The following is a description of a gene set: Enables the transfer of an ion from one side of a membrane to the other. Mouse Gene Set: GOMF_MONOATOMIC_ION_TRANSMEMBRANE_TRANSPORTER_ACTIVITY studied in species Mus musculus, and this is the list of marker genes: Clcn6, Slc34a2, Tmem120a, Chrnb1, Atp13a5, Nherf1, Stim1, mt-Nd6, Slc9b2, Best1, Kcnj6, Slc13a5, Stoml1, Ywhah, Trpc1, Cnga3, Slc24a3, Slc22a5, Cacng6, Slc31a1, Nrxn1, Snta1, Scn5a, Slc18b1, Cacng1 (calcium channel, voltage-dependent, gamma subunit 1), Wnk2 (NCBI Gene Id 75607), Slc26a8, Atp6v1h, Commd1, Tmco1 (transmembrane and coiled-coil domains 1), Atp6v1c2, Atp5me, Rangrf, Flna, Orai2, Pkd1, Atp13a1, Ccdc51, Kcnk2, Slc5a1, Slc6a18, Slc30a3, Cabp2, Kcnj2, Trpc5, S100a6, Atp5pd, Kcnc4, Tmem168, Slc1a7, Ano8, Slc15a4, Asic2, Lrrc8e, Slc34a1, Scn2a, Slc32a1, Grm7, Abcc8, Scn3a (NCBI Gene Id 381367), mt-Nd5, Piezo1, Cacna2d4, Gabrg1, Atp2c2, Gabra5, Atp6v1g1, Cav3, P2rx7, Slc30a4, Kcnmb2, Nrxn3, mt-Atp8, Kcnh3, Slc1a4, Tfrc, Fxyd4, Kcnb2, Slc8b1, Gpd1l, Ucp3, Atp6v0e2, Atp6v1e2, Cacng8, Slc46a1, Hcn3, Magt1, Sfxn1, Sfxn3, Kcna4, Slc12a9, Lrrc8c, Hamp2, Atg5lrt, Kcne2, Kcng1, Atp6v1a, Grik1, Gria1, Calm3, Slc6a14, Micu3, Kcna7, Slc13a3, Chrna6, Grm3, Kcne3, Camk2d, Faim2, Vdac3, Scnn1g, Cacng2, Slc5a4a, Slc25a13, Gabra2, Slc25a27, Kcnj4, Slc25a28, Clca1, Slc2a13 (NCBI Gene Id 239606), Amigo1, Fkbp1b, Ywhae, mt-Nd4l, Pacsin3, Kcnu1, Atp2b2, Slc6a8 (solute carrier family 6 (neurotransmitter transporter, creatine), member 8), Atp6v0d2, Slc6a12, Slc15a1, Slc38a4, Rem2, Slc17a3, Pkd2l1, Ano1, Mlc1, Kcns2, Scn4a, Clca4a, Slc39a13, mt-Nd1, Trpm6, Stom, Grin2c, mt-Co3, Slc12a4, Grin3a, Slc19a1, Grin3b, Tmc8, Kcnk7, Akap9, Tpcn1, Slc9c1, Trpc2, Vti1b (vesicle transport through interaction with t-SNAREs 1B), Cacna1a, Kcnj12, Slc26a9 (solute carrier family 26, member 9), Kcnb1, Kcnt1, mt-Nd2, Calhm6, Slc2a4, Slc26a11, Atp5f1a, Nalf2, Trpv3, Cacng7 (calcium channel, voltage-dependent, gamma subunit 7), Slc10a4-ps, Slc12a5, Apol10b, Lrrc38, Kcnh2, Trpm1, Lamp1, Slc12a3, Kcnj3, Tmem120b, Scn4b, Panx3 (NCBI Gene Id 71631), Slc47a1, Slc10a2, Slc17a7, Zdhhc13, Htr3b, Atp2c1, Gabrr3, Gabrr2, Chrna5, Tmem150c, Slc30a7, Sfxn4, Lrrc26, Kcng4, Prss30, Hcn4 (NCBI Gene Id 330953), Crisp4, Clic6, Slc6a6, Fxyd3, Slc4a2, Slc22a3, Fgf11, Mcub, Kcna2, Slc10a4, Cngb3, Atp6v1f, Slc30a9, Atp4a, Fgf14, Tmem37 (NCBI Gene Id 98701), Kcnn1, Atp5mc2, Slc18a3, Oca2, Trpm2, Prkg1, P2rx5, Slc4a10, Clca4b, Kcnab3, Slc13a2, Stimate, Romo1, Scn9a, Slc30a5, Pkd2, Slc25a12, Kcnk6, Slc10a5, Ano5, Sgk2, Gabrr1, Clcn1, Scn8a, Kcnk13, Pex5l, Nipa2, Cox5a, Sumo1, Apol11b, Atp2a1, Slc24a4, Cox7a1, Slc41a1, Kcnh1, Orai1, Slc9a4, Phpt1, Calhm4, Gria4, Tmbim4, Kcnc3, Atp12a, Chrna10, Kcnmb1, Slc6a2, Atp6v1e1, Clic5, Slc39a11, Slc34a3, Kcnc2 (potassium voltage gated channel, Shaw-related subfamily, member 2), Slc26a2, Cldn4, Slc18a2, Mcoln3 (NCBI Gene Id 22316), Slc25a14, Slc20a1 (solute carrier family 20, member 1), Slc28a1, Glra1, Gabrb2, Clca3a1, Slc9a5 (NCBI Gene Id 277973), Slc12a1, Slc18a1, Slc28a2, Atp13a2, Sec61a1, Cftr, Trpv4, Lrg1, Atp1b2, Stx1a, Apol9b, Gjc1, Slc39a14, Clcc1, Gpm6a, Slc41a2, Kcnd1, Kcnj10, Kcnj13, Gm5134, Kcne4, Chrng, Slc4a8, Apol8, Chrna1, Slc30a10, Slc24a2, Calm1, Orai3, Kcnh6, Tpcn2, Vamp8, Otop1, Slc39a7, Trpm8, Slc16a1, Atp5f1b, Slc6a20a, Slc9a9, Cacna1f, Asic4, Trpm7, Slc4a4 (solute carrier family 4 (anion exchanger), member 4), Scn10a, Cav1, Cldn17, Fgf13, mt-Atp6, Chrna7, Tmc1, Trpv6 (NCBI Gene Id 64177), Clca3a2, Micu1, Tmc2, Snap25, Slc23a2, Itpr3, Kcnk18, Trpc3, Nos1, Sfxn5, Ctns, Gabrb1, Atp6v1d, Clic1, Grik3, Atp7a, Atp2a3, Tmem38b, Ttyh3, Slc5a7, Hamp, Cacnb4, Prkcz, Kcnk9 (potassium channel, subfamily K, member 9), Slc6a7, Cacng5, Gem, mt-Cytb (NCBI Gene Id 17711), Tmc6, Kcnk3, Slc17a6, Tspoap1, Slc26a7, Gabrq, Slc11a1, Lrrc8b, Slc30a2, Mfsd2a, Chrnd, Atp6v1c1, Fxyd6, Atp5po, Bsnd, Chrnb3, Kcns3, P2rx6, Grin2d, Kcnc1, Chrnb2, Nedd4, Tmc3, Slc5a4b, Cnga1, Scn1a (NCBI Gene Id 227987), Cnnm2, Ndufs8, Cacna1g, Aqp1, Ndufv1, Glra2, Chrna4, Kcna10, Slc38a2, Tmem63c, Anxa5, Kcnj8, Mcoln1, Nedd4l, Micu2, Lasp1, Gabrp, Kcnmb3, Trpa1, Grik5, Slc17a8, Atp6v0b, Vdac2, Ndufv2, Slc15a2, Kcnk1, Slc9a2, Atp4b, Ndufs3, Gja1, Abcc9, Kcnf1, Slc30a8, Piezo2, Atp5f1e, Trpm4, Kcnk16, Slc26a1 (NCBI Gene Id 231583), Ano6, Slc5a2, Otop3, Slc30a1, Mcoln2, Kcnd3, Atp6v0a1, Itgav, Atp6v1g2, Gpld1, Pcsk9, Sgk3, Catsper1, Kcne1, Adrb2, Dlg1, Tmem63b, Gabrg3, Kcnj1, Sfxn2, Slc24a1, Calhm1, Kcne5, Atp1b3, Slc5a3, Cacna1s, Fxyd5, Hvcn1, Vdac1, Slc4a7, Clcn5, Slc41a3, Cacng3, Hcn2, Chrm5, Gabre, Atp1b1, Rasa3, Slc6a1, Kcng3, Itpr2, Gabrg2, Slc11a2, Wnk3, Oprm1, Ank2, Slc38a7, Slc46a3, Slc6a3, Calhm5, Clic4, Slc26a4, Htr3a, Gpr89, Kcnq2, Slc39a5, Stx7, Atp2b4, Cox4i2, Slc29a4, Slc4a3, Atp5mc3, Glrb, Atp5f1c, Slc39a8, Nalcn, Calhm3, Nipal2 (NCBI Gene Id 77238), Pkdrej, Scnn1a, Mcu, Slc39a4, Kcnh8, Slc9a3, Nipal1, Cacnb3, Kcnq3, Kcna5, Cacnb1, Slc6a11, Slc4a9, Ryr3, Atp6-ps, Slc6a4, Uqcrh, Cacna1d, Scn7a, Kcnip2, Kcnk15, Kcnh7, Scnn1b, Trpv1, Otop2, Clca3b, Slc5a10, Nmur2, Gabrd, Slc24a5, Rimbp2, Dpp6, Atp5mf, Gnb2, Slc26a10, Kcnq1, Slc30a6, Slc39a1, Nrxn2 (neurexin II), Kcnj5, Tmc7, Kcnab2, Cabp1, Nalf1, Slc25a4, Slc25a3, Stim2, Slc5a9, Ghitm, Cacna1e, Ttyh2, Cachd1, Slc9a8, Asic3, Tmc4, Kcna1, Atp6v0d1, Lynx1, Slc45a3, Slc39a12, Trpc4, Ucp1 (NCBI Gene Id 22227), Cacna2d1, Tmem38a, Slc39a3, Slc8a1, Ano2, Uqcrfs1, P2rx3, Tmbim7, Slc23a1 (NCBI Gene Id 28202), Gja6, Slc39a9, Kcng2, Slc8a2, Kcnma1, Tusc3, Kcnn3, Grik4, Sgk1, Clcnka, Slc1a6, mt-Nd4, Hrh1, Trpc7, Aqp6, Grin2a, Slc39a10, Slc12a7, Slc10a3, Slc39a2, Atp6v0e, Cacna1b, Ryr2, Sclt1, Trpm5, Slc5a11, Cacna2d3, Slc39a6, Psen1 (presenilin 1), Clcn7 (NCBI Gene Id 28069), Htr1b, Gabra3, Kcnk4, Ndufs2, Kcna6, Ndufs1, Cacna1i, Slc28a2b, Slc6a5, Mmgt1, Tmem109, Chrna2, Gria3, Slc45a2, Asic5, Scn2b, Slc5a6, Catsper2, Tomm40, Atp13a3, Cacnb2, Bnip1, Slc26a5, Kcnip1, Kcnj16, Lrrc52, Kcnip3, Scn11a, Kcnk10, Fxyd1, Ndufs7, Ucp2, Slc38a5, Ryr1, Best3, Grin2b, Tmprss3, Slc36a2, Atp1a2, Cngb1, Scn1b, Grina, Asic1, Atp13a4, Slc12a6, Slc38a3, Cyc1 (NCBI Gene Id 66445), Kcnv2, Kcnj14, Slc29a1, Nipa1, Cacna1h, Slc4a5, Kcnk5, Atp7b, Kcnn4, Slc13a1, Atp6v0a2, P2rx2, Shoc2, Cabp5, Slc13a4, Slc6a13, Pias3, Tmem175, Pkd1l2, Kcnk12, Tmc5, Atp2a2, Kcnh4, Slc25a22, Atp6v0a4, Atp1a4, Uqcrh-ps1, Atp5mg, Cnga2, Clca2, Prss8, Kcnq5, Anxa6, Pkd1l1, Slc38a1, Catsper4, Rrad, Slc20a2, Gabrb3, Clcn4, Apol11a, Mrs2, Glrx, Glra3, Slc9a7, Cabp4, Slc26a6, Slc5a8, Slc10a1, Slc47a2, Pacc1, Fxyd7, Slc36a1, Ndufa2, Ndufa10, Arpp19, Atp2b1, Atp6v1b1, Ano10, Slc40a1, P2rx4, Gabra1, Atp5pf, Unc80, Cacng4, Atp5f1d, Mmgt2, Atp5pb, Kcnj11, Atp1a1, Kcnt2, Hpcal4, P2rx1, Kcna3, Trpv2, Grid2, Apol9a, Kcnv1, Catsper3, Slc10a6, Lrrc8d, Kcnn2, Tmem165, Slc6a20b, mt-Co2, Wnk4, Slc12a2, Slc12a8, Atp2b3, Atp6v1g3, mt-Nd3, Chrna3, Ensa, Kcnd2, Rem1, Pde4d, Rack1, Slc26a3, Grik2, Cnnm4, Lamp2, Nnt, Lrrc8a, Slc9a1, Grid1, Wnk1, Atp1a3, Chrne, Gabra4, Tmem94, Slc45a1, Ndufs4, Lrrc55, Kcnq4, Kcnj9, Panx1, Cacna1c, Slc25a5, Prkcb, Slc25a37, Tmbim1, Kcns1, Tmbim6, Tnni3, Dpp10 (NCBI Gene Id 269109), Slc45a4, Nipal4, Calm2, Chrna9 (NCBI Gene Id 69992), Kcnh5 (NCBI Gene Id 238271), Slc8a3, mt-Co1, Ano3, Ano7, Akt1, Trpm3 (transient receptor potential cation channel, subfamily M, member 3), Apol10a, Slc25a18, Gjd3, Chrnb4, Ncs1, Itpr1 (NCBI Gene Id 18544), Grin1, Trpv5, Gria2, Kcnj15, Clcn3, Slc31a2, Slc28a3, Slc6a15, Cacna2d2, Fxyd2 (FXYD domain-containing ion transport regulator 2), Clic3, Slc9a6, Ndufb7, Kcnmb4, Grm2, Slc4a11 (solute carrier family 4, sodium bicarbonate transporter-like, member 11), Slc5a5, Stx8, Surf1, Slc16a3 (NCBI Gene Id 80879), Sting1, Kcnab1, Scn3b, Gabra6, Kcnip4, Pkd2l2, Slc5a12, Ttyh1, Pkd1l3, Fgf12 (fibroblast growth factor 12), Best2, Slc6a9, Slc4a1, Tspan13, Mfsd8, Ano9, Tmem63a, Clcnkb, Slc1a2 (NCBI Gene Id 98863, solute carrier family 1 (glial high affinity glutamate transporter), member 2), Slc22a1, Cpox, Clcn2, Trpc6, Nipal3, Calhm2, Tmco3, Letm1, Glra4, Chp1, Cnga4, Hcn1, Ano4 (anoctamin 4), Atp6v0c, Atp6v1b2, Slc36a3, Atp5mc1, Ptpn3, Slc1a3 (NCBI Gene Id 223326), Slc1a1, Agt, Cybb